Given this list of marker genes CD72, C1QB, OSGIN1, LAG3, AHNAK, MAPKAPK3, SYT11, S100A4, DCPS, CERK, ITGAE, ENTPD1, IRF8, SFN, FGF16, PPP2R5D, EVA1B, POU2F2, TSPAN32, PDK4, NADK, PGAP2, PELI2 (NCBI Gene Id 93480), BMP7, GIMAP1, TGIF1, IGF2R, FRMD4B, SETBP1, ITGAV, SSH1, DTNB, TMEM134, PHETA2, SEPTIN9, AIRN, SESN1, TTPAL, PTGER4, SLC43A2, GABARAPL1, RILPL2, ACOT9 (acyl-CoA thioesterase 9), COTL1, CASTOR1, ST6GALNAC6, ICA1, SPRY1, WARS1, AMER1, VARS1, KCNA3, RAD51B (NCBI Gene Id 5890), MIR34A, CDCP1, KLF8, EPCAM, IRS1 (NCBI Gene Id 3667), ARRDC4, ACOT7 (NCBI Gene Id 11332), SH3BP5 (NCBI Gene Id 9467), CCRL2, TPX2, CENPN, PRC1, SERINC5, ZMAT4, IFT80, CTCF, SOCS5, HDAC7, DYRK1B, WNT3, DUSP16, MEA1, EEA1, IKZF5, LAPTM4B, MIR219A1, RFESD, BHLHE40, MARCHF3, EHMT2, H1-0, CST7, RASIP1, FERMT3, LARP1, NCAPG2, OLFM4, ACAD9, ALDH16A1, CCDC122, UBASH3A, FAU, HDAC6, ANKRD55, PPP2R3A, CD200, CD80, PNRC1, ENDOD1, CPE, RARG, RAB3GAP2, TMEM161A, SNX14, IGFLR1, ATP9A, RCN1 (NCBI Gene Id 5954), NES (nestin), NAGLU, COG7, CAST, POLDIP3, LHFPL1, INPP5F, AMFR, TXNDC12, BCAT1, RIMKLA, SUOX (sulfite oxidase), MXI1, ZDHHC4 (NCBI Gene Id 55146), MYC, PDCD1LG2, CD99L2, XPO7, STAM2, DUSP29, GNS, NIBAN1, CDCA7, MARVELD2, NT5C1B, STARD10, CBLC, GLRA2, ECT2L, CFAP251, FARP1, COL15A1 (NCBI Gene Id 1306), SLC5A7, PLXNC1, LEPROT, CCNE1, CCDC163, CSRP1, SHE, TTC24, PGLYRP1, TRIB1, ASNS, HMGCS1, CCR8, MGMT, SORBS1, IRF1, HPN, MXD4, CDCA3, DHX37, PON3, PCNX1, here is a description of the gene set: Oligonucleotide microarrays were used to establish a profile for gene expression in wild-type airway epithelial cells after paramyxoviral infection. Analysis was performed on mRNA isolated from SeV-infected primary-culture mouse tracheal epithelial cells that were maintained under physiologic conditions (air-liquid interface). Genes down-regulated in tracheal epithelial cells infected with UV inactivated versus intact Sendai virus. from publication Shornick LP, Wells AG, Zhang Y, Patel AC, Huang G, Takami K, Sosa M, Shukla NA, Agapov E, Holtzman MJ (PMID 18292557) Human Gene Set: GSE10211_UV_INACT_SENDAI_VS_LIVE_SENDAI_VIRUS_TRACHEAL_EPITHELIAL_CELLS_DN studied in species Homo sapiens